Given this list of marker genes LAMB3, LAMB1, LAMA3, LAMA2, LAMA1, LAMA5, ITGB4, LAMC2, LAMC1, LAMB2, ITGA6, here is a description of the gene set: Human Gene Set: PID_INTEGRIN4_PATHWAY from publication Schaefer CF, Anthony K, Krupa S, Buchoff J, Day M, Hannay T, Buetow KH (PMID 18832364) studied in species Homo sapiens Alpha6 beta4 integrin-ligand interactions